The following is a description of a gene set: A cytosolic protein complex that is capable of activating caspase-1. species: Homo sapiens Human Gene Set: GOCC_CANONICAL_INFLAMMASOME_COMPLEX, and this is the list of marker genes: AIM2, CASP5, PYCARD, MEFV, NAIP, CASP12, DDX3X, NLRP3, CASP4, NLRC4, NLRP6 (NCBI Gene Id 171389), NLRP1, CASP1 (caspase 1), GSDMD, NLRP9 (NCBI Gene Id 338321), DHX33, CARD8